Given this list of marker genes PROM1, BASP1, PTPRO, MYO1E, FOXC1, EDNRA, CD24, IQGAP1, CD34, PECAM1, NPHS1, FOXC2, ASXL1, JAG1, ADIPOQ, NPHS2, FOXJ1, AMPD2, EDN1, LAMB2, KLF15, EXT1, WT1, NOTCH2, PODXL, MAGI2, EDNRB, CD2AP, here is a description of the gene set: Human Gene Set: GOBP_GLOMERULAR_EPITHELIUM_DEVELOPMENT The process whose specific outcome is the progression of the glomerular epithelium over time, from its formation to the mature structure. The glomerular epithelium is an epithelial tissue that covers the outer surfaces of the glomerulus. The glomerular epithelium consists of both parietal and visceral epithelium. Metanephric glomerular parietal epithelial cells are specialized epithelial cells that form tight junctions as a barrier to protein transport. A metanephric glomerular visceral epithelial cell is a specialized epithelial cell that contains 'feet' that interdigitate with the 'feet' of other glomerular epithelial cells in the metanephros. species: Homo sapiens